The following is a description of a gene set: species: Homo sapiens Human Gene Set: ZBTB44_TARGET_GENES Genes containing one or more binding sites for (ZBTB44) in their promoter regions (TSS -1000,+100 bp) as identified by GTRD version 20.06 ChIP-seq harmonization. from publication Yevshin I, Sharipov R, Kolmykov S, Kondrakhin Y, Kolpakov F (PMID 30445619), and this is the list of marker genes: LAMP1, SCML4, ENSG00000224865, THYN1, UBB, LRIG3, HTT-AS, PEMT, ERBB3, SETD7, LINC01965, ATXN2-AS, RUBCN, ZFX-AS1, IFI6, LINC02739, VLDLR-AS1, PSIP1, FAM149A, ATP6V0D1-DT, TSEN15, EPC1, TXNRD1, MEGF10, RNF144B, GATA2, BRF1, KSR2, CDK11A, PCM1, CENPT, ST7, PIAS4, FAT3, NOP10, MRPL34, TBL1X, CCDC144BP, RPTOR, CHCHD2P1, WDR26, BICRAL, PXK, POC1A, SPRING1, KLKP1, ZFX, NOSIP, TRIM8, TEX261, HOXC4, GGNBP2, AKAP1, MED15, DBP, EPCIP-AS1, SLC35E2A, KDM2B, TMEM52, TRMT2A, SUGT1, RNU4-1, AP3B1, FGF9, ATP2B4, AGTPBP1, WDR37, FBXL9P, IGFLR1, PAPSS2, CSRNP2, CCDC192, MIR449C, TSTD2 (NCBI Gene Id 158427), INHBE, ZNF609, LINC02643 (NCBI Gene Id 105376444), FOXP2, MCM3, CLCN3, PIK3IP1-DT, TMEM208, JAKMIP2, FAM133A, YARS1, HEXA (NCBI Gene Id 3073), ORMDL3, NELFB, ACBD5, SEMA6D, AFF4, ZMYND8, EMX2OS, TP53I13, TPD52L1, SEMA7A, RBL1, LINC01089, EGLN2, NDUFS6, MARK4, GNAL, BICDL1, SNORD118, LRRC1, CDC42SE1, ADGRF2P, NEGR1, CCDC106, TP73-AS3, CASTOR3P, BMF, LMNB1-DT, H2AC11, YPEL3, ATF7IP, KMT5A, NRN1L, CDC42BPA, PPP1R3D, CEP135, ABCG1, PTK2, RNU4ATAC16P, CEBPA-DT, ANAPC10P1, HAP1, FAM222A, PIEZO1, CASKIN2, RBM28, TRIM2, STC1, WDR70, FABP5P3, TFAP4, PGAM5, TGFBR3L, PIM1, INTS12, RAI14, PRRG2, PTCH1, WNT10A, AATBC, GTSF1, KCTD5, TMCC3, GCHFR, MCMBP, IFI27L1, LIMA1, RNU6-920P, USP22, PTPRD, ERGIC2, EML2 (NCBI Gene Id 24139), ZNF155, TBC1D16, HOXC6, PIPOX, ATP2C1, MRPL55, MVP-DT, OGT, RRP1, UBE2F-SCLY, BPNT1, UBE2E1, CAND1, MTARC1, PPCS, MAP4, ELP3, EFHC1, DLX2, ZNF233, HNRNPD, HOTAIRM1, TSEN54, LTBR, BAX, SPRY2, EDEM2, RNU6-360P, LRP8-DT, CWC25, HPF1 (NCBI Gene Id 54969), ASPH, NR2F2, CCNO-DT, SMAD1, LRP8, ETHE1, PPP1CC, TSEN2, RO60, ADGRB2, ULBP1, TM7SF2, REEP2, FYTTD1, FASTK, STOML1, TEF, GUSBP1, RAB2A, ZNF575, ACAT2, CSDE1, LGALS8, YAP1, ZC2HC1A, PGK1, SH2B3, MAN1C1, LGALS8-AS1, HEBP1, PKN2, TMEM134, PTPA, YWHAZ, AARS2, RFTN1, BEND5, GRK6, SLC11A2, FMN2, FBXW9, LINC01275, CATSPERG, PXMP2, TNC, KTI12, ZNF875, SLX4IP, RNF43, DRG2 (developmentally regulated GTP binding protein 2), PLCH1, RTEL1-TNFRSF6B, FYN, FOXN4, ANKDD1B (ankyrin repeat and death domain containing 1B), SPAG8, BCAR3-AS1, DHRSX, PDCD6P1, RBMS3, PHOSPHO1, MTUS1, REEP5, VPS51, NIPBL, ENPP3, PURA, CENPU, C11orf52, RGS20, ZNF428, LINC01775, ATXN7, LYPD5, RBM17, PLCE1, LINC02470, HOXA1, LRIG3-DT, SSX2IP, EPRS1, SPSB1, RASSF4, ALKBH3-AS1 (NCBI Gene Id 100507300), L3MBTL3, PRSS23-AS1, BSCL2, ZFC3H1, SIX1, SLC16A14, EOLA1, CSTBP1, DZIP1L, ATF6, IFT81, TGIF2, DNAJC6, CDKN2AIPNL, GLI3, ORC4, VPS13B, HEXIM2, STK40, SINHCAF, CELF2, MIR615, STUM, MTF2, DSTYK, KBTBD2, PRUNE2, GNPTG, CKB, RABGAP1L, H4C3, ATN1, PCSK6-AS1, NUP43, RRP1B, ADAM11, KLRK1, ADAMTS6, SLC16A2, HOXB8, LASP1, SLC25A27, POLR1F, TBC1D10A, SEPHS1, RESF1, ZBTB38 (zinc finger and BTB domain containing 38), GSPT1, FCHSD2, CSNK1G3, PMM1, GEM, RAB30-DT, KLF7, MBD5, TPD52, PGAM1P5, NCAM1, ABCB9, NCBP1, ZYG11B, DNAJC19P7, AKAP11, COMMD2, KDM1A, MALAT1, PIWIL2, N4BP1, ALDOA, RTEL1, DGLUCY, MIR7845, ZDHHC8, RNF145, ATXN2, RBMS3-AS3, GEMIN7, PLK3, EFNA5, MARVELD3, KCTD14, EIF2B5, TLE6, CITED2 (Cbp/p300 interacting transactivator with Glu/Asp rich carboxy-terminal domain 2), IGF1R, GNG3, KATNB1, NBEA, PTK7, USP31, PPIAP19, CDH3-AS1, COG2, STX4, UBE2F (ubiquitin conjugating enzyme E2 F (putative)), MGC32805, LRRC41, PSPC1, GABPB2, SCAF8, SIAH1, ITGA8 (NCBI Gene Id 8516), PHAF1, ZBED3-AS1, SRCIN1, RPL39P40, PPFIBP1, MDM2, LINC01976, SUGT1-DT, CCT6B, PIP4P2, AMACR, LCORL, LINC02960, FAM217B, MAP6, FAM174C, PARP16, ENSG00000267174, ENSG00000246465, CABLES2, TRADD, LINC02288, ANKRD18B, MSH3, CHRNA9, KRTAP9-12P, ADGRL1, MICALL1, CSK, DLC1, PTEN, C1orf35, ARHGAP18, VWA7, ZCCHC4, RNU6-532P, BASP1-AS1, LMO4, CCPG1, PRKAB2, HOXA3, SSBP2, RNF217, ZMIZ1-AS1, TRERF1, RBBP5 (NCBI Gene Id 5929), AFF4-DT, EPB41L4B, SLC38A1, CSRNP3 (cysteine and serine rich nuclear protein 3), KLHDC9, TMEM79, PAXBP1, RNU7-29P, BAZ2A, ENSG00000266100, PBK, GALNTL5, SUB1, CHSY1, DHRS13, FBXO31, ZNF581, DUSP6, NTN4, KIAA0319L, TLK2, CACNB2, ABHD12, DHFR, STMN3, MIR4727, HMGN3, AVPI1, LGALS1, EMX2, TXNL1, DOC2A, GAPDHP14, HTR3A, PRR12, TBL1XR1, ELF1, RNF182, PHF21A, CASZ1 (castor zinc finger 1), FAF1, AKAP7, RBM27, ZC3H12C, IFI44L, RHOF, MIR759, BLCAP, WDR7, APOLD1, USP3, SLC35C1, TNS2-AS1, MAML1, B3GALT4, DLGAP4-AS1, ADNP, WDR6, LHX6, ZNF510, EFEMP2, MKKS, IGFBP5, RPS26, SARAF, YPEL3-DT, GTF2IP4, TSR3, ST6GALNAC2, EXTL2, MAP1LC3B, ARHGEF6, SMG8, AURKAIP1, ARL14EPL, SOCS2, FAM3C, RFFL, CROCC, SPAG7, MAPK8IP3, TM7SF3, ITPRIP, HOXA9, TBC1D9, DDX24, CCDC33, ARID5B, THAP2, LINC02609, LINC02846, SMAD5, EMC4, PDE4D, NDUFS7, PPP2R2B, BCRP2, VAMP1, YARS2, SLFN12, DRAP1, TJP3, NFE2L1, FBXW2, C11orf68, NMT2, LRRC49, OMG, KDM2A, HEXIM2-AS1, CRADD, CAPNS1, FBRS, SMG5, RPGRIP1, IRAIN, SLC30A4-AS1, GTPBP3, MBNL1, DHTKD1, TFAP2A, BBC3 (NCBI Gene Id 27113), PPP6R1, CEBPA, PRRT3-AS1, C6orf52, LINC02198, PPP4R3A, DPP8, DLX2-DT, ZNF608, USP44 (ubiquitin specific peptidase 44), ZNF580, C15orf39, SCN8A, KMT2A, ENAH, MDC1, MRPS15, CFAP74, DCAF8-DT, MED23, PLAG1, SRCAP, SLC39A3, ADGRF4, DDIT4, UCHL5, PIK3IP1, GSTCD, LINC02980, FREM2, TGIF1, CUEDC1, ZMYND12, CCDC183, BACH2, EYA3, LRP6, B3GALT9, GALNT12, RNU7-27P, HOXB9, TBCC, CAV1, NFIB, TTC13, UBC, EBF3, EGFEM1P, F12 (coagulation factor XII (Hageman factor)), UBE2O, CTNNA1, DYNC1I2, JPX, FOXN2, WDR62, PCBP2 (poly(rC) binding protein 2), MGRN1, CHD9, CLASP2, OCEL1, HSF2BP, SEC1P, ASCC1, LDHA, CHIC2, FBXL20, VGLL4, SMU1, IER5L-AS1 (IER5L antisense RNA 1), SIAH2, VLDLR, GLS, SAMD4B, BMPER, TRIM8-DT, FIS1, MAPK4, ZMIZ1, ETF1, MRPL4, CLDN7, GBA1, FGD4, CLIC4, DLX6, NOL4 (nucleolar protein 4), LINC02598, GNB2, C19orf47, BASP1, FRYL (NCBI Gene Id 728298), PIERCE2, HOXA-AS2, LIG3, LINC01750, LRFN2, CHCHD7, CACNA1D, DPYSL5, PDE4B, ZNF394, MKLN1, TUBA1A, ADAM22, FBXL16, ZNF217, POC5, CCNO, ACAD8, LGR4-AS1, INTS10, ANXA11, TMOD1, TMEM14C, RAPGEF4-AS1, TRIB3, MIR5188, ACVR1, MAP2K5, NUTM1, H3-3A, LINC02136, RNU6ATAC34P, NDUFB7, STMND1, NANS, TSC22D4, SERPINI1 (serpin family I member 1), LINC02028, TMCC2, NOG, RAB30, CUEDC2 (NCBI Gene Id 79004), DISP1, CDKL5, SBK1, ZNF281, ARV1, FBXO32, FRY, HTR7P1, PLD1, NFIA, ZBTB17, KMT2C, CBX4, ATG5, ASPSCR1, POLE, ERCC5, PIP5K1B, ANXA9, ARHGAP29, NLRC5, RWDD1, NAP1L2, NEDD4L, LINC02810, SYNPO2, ARB2A, DYNC1I1, ZNF416, TSHZ1, C5AR1, PRR14L, CRIPTO, CFDP1, ENO3, NAT8L, RPL30P11, CHD2, URI1, ANKRD40, MARCHF8, PLAC8, MACF1, CCBE1, BAHD1, POLE4, MRPS31, TFEB, CSNK1G2, LMNB1, NAA16, TLCD3B, ANKRD13A, PRKCE, ANK3, PDK3, AMN1, SLC16A6, DCP1A, ENSG00000247416, HEATR1, RSPO3, SUZ12P1 (NCBI Gene Id 651491), CRYBG1, NREP, RNF220, PDCD10, ANO8, HIP1R, GAS1, EMC9, PRICKLE2-AS3, MAST4, CRNKL1, CYP39A1, G6PC3 (NCBI Gene Id 92579), CALD1, SAMD11, ACE (angiotensin I converting enzyme), HNRNPD-DT, NCOA7, MIR99AHG, CLTC, LINC00330, STK17B, ENSG00000275740 (novel readthrough transcript), CLN8, ZNF815P, HERC5, KDM2B-DT, CDKN2C, RPL27, BICD1, ZBED3, HEXA-AS1, ZZZ3, TMEM101, ADD3-AS1, NCDN, SEMA3C, RPL36P5, FLT3, NKPD1, ATP6V0D1, TOP3B, TSC22D2, RANBP1, EOLA1-DT, ERBIN-DT, ADIPOR1, ARID1A, RERE, SETD5, POLR3E, SMARCD2, RCAN1, SEMA6A, LNC-LBCS, HNRNPU, STAT6 (NCBI Gene Id 6778), TNS2, PLD3, JADE1, ZNF668